Given this list of marker genes BCL11B, SASH3, SMARCAL1, PSMB10, IL2RG, POLD3, IRF1, SYK, PIK3R1, POLD1, FOXN1, here is a description of the gene set: studied in species Homo sapiens Any abnormality in the proportion of naive T cells relative to the total number of T cells. Abnormal naive T cell proportion Human Gene Set: HP_ABNORMAL_NAIVE_T_CELL_PROPORTION